Given this list of marker genes ING1, SMAD3, RPL7P50, NDUFS3, STK25, FERRY3, TRIM36, PCAT14, RCOR2, AP4M1, NDUFAF1, AURKAIP1, GATB, NSA2, MIR5188, VARS1, IFRD2, CEP112, SEC14L1, PKP2, UBR5, MIR638, U2AF2, FAAP24, NOXA1, SNORD12C, DNM2, IKZF5, DOCK2, RNVU1-30, PWWP2A, MED23, GNAS, MRPS17, PCBP3, NMNAT1, MRM3, UTP4, SGMS1-AS1, MIR153-1, CHCHD10, LINC02391, VDR, MYCBP2, MAFA, PRR11, CP (NCBI Gene Id 1356), PAG1, TRIB1, SYT7, LINC01798, SSBP2, BFAR, COPS2, WDR83OS, CDYL, HEXIM2-AS1, WDCP, NAV3, TPST1, MED26, LINC03108, ZNF609, TMEM94, ARHGEF2, CTBP1 (NCBI Gene Id 1487), FOXK2, SPRED2, PDE12, XPO1, ODAD2, PARN, C8orf33, HNF4A (NCBI Gene Id 4339), LAMP1, GNPTG, CSGALNACT2-DT, ZC3HAV1, UPF2, MCRIP2, ENSG00000267698, PECAM1, PET100, MCCC1, CDC20, SLX9, SNRNP200, ZNF280D, DUSP19, RRAGA, CHD9, INVS (inversin), PSMD4, NSL1, GLOD4, RER1, KCNH1-IT1, ST20, TOP2A, PSAP, CIC, SGMS1, SLC22A23, AQR, ST3GAL1, BMF, ANKRD39, ZNF689, CCL3, OSBPL2, KAT8 (lysine acetyltransferase 8), PADI1 (NCBI Gene Id 96201), ANKRD23, RAP2B, KLHL20, CHMP4B, BRINP2, SP2, RSF1, GALK2, LINC01460, SSR3, ANKRD54, ACBD4, ZNF341-AS1, RUSF1, ENSG00000283078, TMEM184C, MYO15B, TATDN3, PRDM2, DENND10, ZFAS1, VMP1, AIRIM, CYP51A1-AS1, GDAP2, LINC01480, TSR3, SLC22A4, NCLN, CEP89, ERCC1, ANKRD16, LINC01962, MXD3, WDR3, ILF2, POLR2D, WDR31, SYMPK, ADD1, HRAS, MAP2, LNC-LBCS, TRAF1, ZMIZ1, GTPBP3, ID2-AS1 (NCBI Gene Id 101929606), BACH2 (NCBI Gene Id 653980), EMX1, H2BC10, ENSG00000236846, WIPI1, DYM, SAP30BP, WDR24, TARS2, MPP7 (NCBI Gene Id 143098), NFATC4, RAB5B, WASL, AFF3, COMMD1, NUP50P2, TYK2, EXD3 (NCBI Gene Id 54932), GABBR1, ERC1, CCT4, ENSG00000266401, FAM3C, GFM2, ZNF37BP, MAP1LC3B, ATP5MG, CENPX, PIGV, DDOST, ANXA2R, TELO2, PARAL1, FBXL19, CCNL1, RBBP5, SELENOH, IPP, TRAPPC9, CCNI, LRRC45, IARS2, ARID1A, DGKZ, WAPL, INSR, CDYL-AS1, RNF2, HJV (NCBI Gene Id 9974), FHIP2A, LY9, DCP1A, RN7SL108P, PAXIP1-AS2, RAD51AP1, CYP51A1, LINC00431, ALKBH7, CTBP1-DT, RBM47, MDH1, C11orf68, SSBP1, MUC20-OT1, COPE, SEC22C, CTU2, ENSG00000261335, PDGFC, GRK6, ABITRAM, DDX1, ZNF484, EML2, TJP3, CEP250, MIR100HG, RNU6-1158P, SMARCE1, USPL1, UBAC1, AK2, STPG1, ZFAND2A, RNU5E-4P, PFDN4, DENND4A, RIIAD1 (regulatory subunit of type II PKA R-subunit domain containing 1), ZNF669, LINC01348, ANKEF1, IFI44L, HM13-AS1, TPM4, XBP1, TSBP1-AS1, TCEA2, GPBP1, CDCA8 (NCBI Gene Id 55143), BANP, CLPB, NCBP2AS2, SLC9A1, PIM1, CHTF8 (NCBI Gene Id 54921), FHAD1, CYP2R1, TLDC2, MCM7, ZMYND8, ALKBH6, KCNH1, CALM1, NDUFAF8, KIF16B, SNORA48, PMEL, STAT1 (NCBI Gene Id 6772), FBXL19-AS1, RABEP1, ANKRD36BP2, AAMDC, THOC5, NSUN2, DPP9, EMG1, ITGB7, ZFAND2A-DT, LINC01873, RNF213-AS1 (NCBI Gene Id 100294362), HSD17B12, LIMK2, SKIL, NUP88, CTNNB1 (catenin beta 1), HRCT1, NCOA7, GOT2P7, IRX5, WDR83, FHAD1-AS1, NPC1, ITGB1BP1, CELF3, LRRC14B, LINC02960, LINC01719, FBH1, AP2A1, PTPN6, PAFAH1B2P2, RBM45, NOC4L, SRD5A1, BAZ2A, KIAA0825, LRP3, AXIN2, RAB40B, DMAP1, TRIP10, FSD2, SPSB3, GLUD1, PLAC1, LINC02084, CHD6, SMCO1, KPNB1, ERP44, NABP2, EIF4A2, ATN1, FBXO3, ATP2C1, FLYWCH1, CPSF3, ZFYVE26, ZNF131, INTS4, TEPSIN (TEPSIN adaptor related protein complex 4 accessory protein), WASL-DT, URB2, MIR802, TAF5L, RNU5F-1, EIF2D, XAB2, AKNA, MRPS18C, UNK, LINC01776, MAPKBP1, H4C4, H4C2, MTRF1, ATP5F1E, GDF5, NDUFV2, H2AC10P, SNORA13, STIP1, SIRT6, CMAHP, NCBP2, PIP4K2A, LINC02015, ZNF268, KATNB1, DRAP1, MAP3K8, SLC1A5, PTEN, LY6S-AS1, SEPTIN9, ZNF486, POLR3F, RGL1, PXMP2, EPS15, RAD51AP2, CALCOCO1, BUB1, CALM3, NSUN4, KLF5, LAS1L, MFAP3L, EHF, ZNF395, ENPP4, RPS14, METTL26, RAD51B, ADAMTSL4-AS1, MXI1, RECQL5, RHOT2, ZNFX1, SFSWAP, DIPK2A, KCTD1 (NCBI Gene Id 284252), MCM8, SNX16, CITED2, TM2D1, SKA2, EMCN, ADAMTSL1, FUT10, CARS2, IGSF8, H2AC12, VPS50, FAM111B (NCBI Gene Id 374393), TNFAIP8L1, CCNC, RFX1, TCF3, AMOTL2, STX16-NPEPL1, SNAPC4, ACADSB, HDAC5, SLC5A6, DHX8, TRDMT1, HMGB1, LINC00352, ZNF451, FBXO38-DT, SMARCD2 (NCBI Gene Id 6603), CABLES2, AP1S3, LINC01547, LINC02240, PDPK1, GPR108, EGR2, THADA, FBXO15, MAPKAPK5, ING4, CLPTM1L, EIF4A1, TIMM21, VRK1, DDX39B, OTUD7B, IFNAR2, FGF22, MIR125B1, NR6A1, MIR133A1HG, ELP1, GFI1B, PPP1R37, FABP5P3, H2BC12, GLMP, CENPU, WT1, PSMF1, RNVU1-19, CTDP1, PHF12, TMEM256-PLSCR3, KIF1B, OAT, FEM1A (fem-1 homolog A), STAU1, ALG10B, ENSG00000275635, ANKRD11, C2orf42, INTS10, CMSS1, BPNT1, TRIM7-AS2, GSK3A, SPRED1, TAF15, FAM117A, ZSCAN12, EPB41L4A-AS1, MIR548AW, UBIAD1, BBX, LZIC, SUZ12P1, TXNDC11, TSN, CPSF6, COA1, SLC66A2, PROSER3, STK17A, TCF12, MYOM2, CCDC144BP, RGS16, FOXP2, DDX39B-AS1, SHLD2, KLF6, BEND3, JCHAIN, CDC20-DT, SLF1, CSGALNACT2, CNOT1, KMT2C, ARRDC3, CCL5, MNT, KBTBD4, SINHCAF, KDSR, RNU4-1, TBL1X, TSTD1, PSCA, NFIB-AS1, VTRNA1-1 (vault RNA 1-1), DDX51, EVI5L, WDPCP, ANKRD24, UBC, KCNN3, FBXO11, WAPL-DT, LIG3, DZANK1, TXNDC5, H1-4, HDAC9, RPL32, INTS1, NIPSNAP2, MKKS, ZNF773, ZCCHC4, MIR1289-1, RAP2A, ACTR2, LINC01124 (NCBI Gene Id 440925), SCRIB, TAF4, KRT23, PANK4, AP2S1, LINC01186, MADCAM1, FAP, RNVU1-6, RRAS, BARHL1, POLE, H4C3 (NCBI Gene Id 8364), TSC1, MORN1, HNRNPC, TK2, TMEM245, CWC15, PIPOX, POLG, MYLIP, ATL3, TIMM22 (NCBI Gene Id 95988), ECT2, IRF1, ZMIZ1-AS1, EDIL3, FRS2, NLGN2, PEMT, FASTKD1, RWDD1, NUDT16-DT, AIFM1, LINC00963, STOML2, IRAG2, NLK, RNU6-351P, PRPF18, ALDH1A1, CRLF3, ZNF608, KAT7, TLR5, SP5, FBXO31 (F-box protein 31), HELQ, CISD1, ZC3H6, AKR1E2, LINC02551, USP3, RN7SL847P, HSPB6, HEXIM2, GAPDHP2, RPAIN, RASA2 (RAS p21 protein activator 2), NUBP2, SH3GL1, MSR1, SPG7, EPRS1, MIR3143, LTBP4, ATRAID, TMEM184C-DT, GCLC, TRAPPC12-AS1 (NCBI Gene Id 100861515), TDRD7, KDM4D, LINC02090, MAPKAPK5-AS1, H3-3B, AP3S2, FOXK1, TMEM256, SLX4IP, PDP2, ARID5A, NOP16, PHF1, PUM3 (pumilio RNA binding family member 3), MMP11, STK11, MALAT1, U2SURP, RNF166, TBL1XR1, JRK, RAPGEF1, MMP20, SAXO1, NDC1, AP3B1, RPS26, NTHL1, NUDT16, KAT6A, IRF2BPL, NMI, POLG-DT, PPP5D1P, OR4H12P, TSC2, PHB2, IFTAP, RPS7, NAA35, SHB, ENPP3, SNORD84, WEE2-AS1, LINC01132, TNFRSF17, ENSG00000233230, CDCA3, NEK10, PIP4P2, SLC33A1, EVI2A, NDUFAF4P1, TM4SF18, ENDOV, VPS13D, CRACDL, ENSG00000268129, CAPS2, ADGRL1, DIMT1P1, NR1H2 (nuclear receptor subfamily 1 group H member 2), HSH2D, INO80C, KANSL3, FBXO38, DDX49, BOD1, MTMR14, STX16, XPOT, BMAL1, TRMT6, THNSL2, KMT5B, DLGAP1-AS1, here is a description of the gene set: Genes containing one or more binding sites for (HDAC4) in their promoter regions (TSS -1000,+100 bp) as identified by GTRD version 20.06 ChIP-seq harmonization. studied in species Homo sapiens from publication Yevshin I, Sharipov R, Kolmykov S, Kondrakhin Y, Kolpakov F (PMID 30445619) Human Gene Set: HDAC4_TARGET_GENES